Given this list of marker genes FGFR3, RAB34 (RAB34, member RAS oncogene family), TBXT, B9D1, PLXND1, TXNDC15 (thioredoxin domain containing 15), BMPER, ZSWIM6, COG8, KMT2D, here is a description of the gene set: Late first trimester onset This term refers to a phenotypic feature that was first observed prior to birth in the first trimester during the early fetal period, which is defined as 11 0/7 to 13 6/7 weeks of gestation (inclusive). studied in species Homo sapiens Human Gene Set: HP_LATE_FIRST_TRIMESTER_ONSET